The following is a description of a gene set: Mouse Gene Set: ZENG_GU_ICB_CONTROL_METAGENE_42_PRECICTIVE_ICB_RESISTANCE Metagene derived from the control samples, found to be predictive of immune checkpoint blockade treatment resistance, not otherwise discussed. from publication Zeng Z, Gu SS, Wong CJ, Yang L, Ouardaoui N, Li D, Zhang W, Brown M, Liu XS (PMID 36240281) Most patients with cancer are refractory to immune checkpoint blockade (ICB) therapy, and proper patient stratification remains an open question. Primary patient data suffer from high heterogeneity, low accessibility, and lack of proper controls. In contrast, syngeneic mouse tumor models enable controlled experiments with ICB treatments. Using transcriptomic and experimental variables from >700 ICB-treated/control syngeneic mouse tumors, developed a machine learning framework to model tumor immunity and identify factors influencing ICB response. Projected on human immunotherapy trial data, found that the model can predict clinical ICB response. further applied the model to predicting ICB-responsive/resistant cancer types in The Cancer Genome Atlas, which agreed well with existing clinical reports. species: Mus musculus, and this is the list of marker genes: Micos13, Stx7, Mpl, Extl1, Igsf8, Stk33, Mucl1, Supv3l1, Chn1 (NCBI Gene Id 98942), Ivd, Dmbx1, Bola3, Hspb9 (NCBI Gene Id 75482), Ndufc1, Cimap1c, Ptdss2, Ndufaf7, Chaf1b, Wbp1, Ctnnal1, Atp6v1c1, Hsf4, Rufy4, Ankrd39, Dnase1, Clptm1, Ptger1, Ran, Speg, Bbs7, Ddo, Mrpl58, Mro, Anapc16, Atp13a2, Ggact, Txn2, Ankrd24, Sppl2b, Mpnd, Syne2, Tfpt, Adgrl2, Scly, Ephx1, Agt, Best3, Cfap70, Ino80b, Svop, Eif4enif1, Washc1, Gypa, Ifi44l, Cenps, Mfsd4b5, Cabp7, Etfb, Raet1d, Gbx1, Cfap410, Kbtbd4, Ppp1r7, Rnf157, Kcnj14, Lrrc57, Klhl22 (kelch-like 22), Selenbp2, Ndufab1, Arhgap6, Coa3 (NCBI Gene Id 68213), Moap1, Efcab12 (NCBI Gene Id 212516), Cd59b, Otos, Klhdc1, Slc35f3, Neu1, Sirt3, Trub2, Coq6, Gamt, Mef2b, Nmbr, Iah1 (NCBI Gene Id 68993), Dmac2l, P3h2, AU022252, Hmgn1, Fastkd2, Spata33, Cplane2, Mapk4, Prss41 (NCBI Gene Id 71003), Tspyl4, Atp1a4, Lrrc75b, Metap2, LTO1, Chchd10, Ndufs1, Smim1, Rgp1, Polr2i, Espnl, Zfyve21, Evc, Fuz, Cdkn3, Akt1, Abtb1, Ciao3, Uggt2, Dctn3, Mff, Ppfia1, Hagh, Pdcd2l, Ndufa3, Fsd1 (fibronectin type 3 and SPRY domain-containing protein), Eif2s1, Sec14l2, Dnajc24, Skida1, Ift81, Lhfpl3, Tatdn3, Adsl, Rasgrp2, Eif3l, Nt5c2, Amdhd1, Xpa, Scamp4, Nif3l1, Ndufaf6, Paqr6, Psmc6, Hax1, Eml2, Slc18b1, L3mbtl2, Adi1, Pcdhb14, Oxnad1, Actr1b, Ttc23, Capn10, Nipsnap1, Tmie, Dpf2 (NCBI Gene Id 78490), Rps27l, Ppt2, Fah, Phospho1, Sdhc, Tysnd1, Mapre1, Depdc7, Csnk1g2, Hoxd13, Wnk4, Cth, Uroc1, Kctd15, Ss18l2, Fuom, Pdrg1, Ift88, Oaz3, Uri1, Idh2, Micos10, Spata17, Lrrc47, Caps2, Gng3, Lrrc27, Lrrc24, Rbpjl, Parl, Pigp, Ppp5c, Plin3, Pex7, Dzip1, Ptges3l, Slc39a3, Fhl5, Gpr137b, Ccdc38, Prodh, Rbpms, Chid1, Ak3, Ppil3, Smdt1, Cttn, Rnf207, Aph1b